The following is a description of a gene set: from publication Chen Y, Wang X (PMID 31504780) Mouse Gene Set: MIR_291A_3P_MIR_294_3P Genes predicted to be targets of miRBase v22 microRNA mmu_miR_291a_3p, mmu_miR_294_3p in miRDB v6.0 with MirTarget v4 prediction scores > 80 (high confidence targets). species: Mus musculus, and this is the list of marker genes: Lhx8, Txnip, Nhsl3, Med12l, Krt222, Akr1c21, Mtus1, Yod1 (NCBI Gene Id 76190), R3hdm1, Fzd3, Mospd2, Slc49a4, Kcnb1, Rab11a, Marchf8, Rps6ka1, Tle4, Skida1, Marchf11, Asap1, Pde3b, Myrf, Pcdh7, Pou6f1, Ube2q2, Tmtc1, Vmn1r45, Twf1, Prdm8 (PR domain containing 8), Retreg3, Asf1b, Zfp800, Ccnj, Unc80, Pak5, Mylk, Tet1, Synpo2, Uap1, Mtmr3, Fgd4, Crim1, Unk, Ythdf3, Cdkn1a, Nr2c1, Cnot6, Kat2b, Rab22a, Bcl11b (B cell leukemia/lymphoma 11B), Kmt5b, Fndc3a, Rock2, Prdm4, Cyp26b1, Asxl3, Vldlr, Nufip2, Tiparp, Ccnd1, Rbl1, Gpr158 (G protein-coupled receptor 158), Parp8, Zbtb41, Tmem123, Ube2b, Spop, Caprin2, Dcaf6, Ambn, Rnf150, Micu1, Zfp362, Ism2, Nr2c2, Slc5a10, E2f2, Ppp1r36, Lefty2, Hs2st1, Flt1, Plagl2, Unkl, Npas3, Armc8, Fam168b, Slc7a2, Erap1, Glis3, Zfyve26, Trpv6, Tfap4, Slc30a10, Ptpn21, Snx8, Slc22a23, Rb1cc1, Lats2, Hmbox1, Asf1a, Ddhd1, Dgkq, Dcdc2a, Arhgef17, Ryr2, Prdm16, Zkscan1, Taf1, Zfp827, Cdk6, Irf2, Nfib, Ssr1, Zfp148, Irf9, Sar1b, Zbtb43, Ednrb, Cpeb1, Ddias, Dpp8, Phc3, Epha2 (Eph receptor A2), Epha5, Sf3b1, Aak1, Mpc1, Ezh1 (enhancer of zeste 1 polycomb repressive complex 2 subunit), Wdr48, Macc1, Dcun1d4, Hlf, Erc1, Pak2, Nfia, Golga1, Srcin1, Ago1, Zfp367, Cdca7, Ikzf2, Tmub2, Zfp9, Tgfbr2, App, Zfp53, Rnf6, Ss18l1, Mettl21c (methyltransferase 21C, AARS1 lysine), Lhx6, Ptprb, Kpna2, Col17a1, Trim36, Mink1 (NCBI Gene Id 50932), Kif26b, Pip4k2a, Crot, Ash1l, Reep3, Smarcc2, E2f7, Clock, Coro2b, Miga2, Jazf1, Tnfaip1, Irf2bp2, Elk4, Rassf2, Bloc1s5, Rab5c, Suv39h1, Kremen1, Tiam1, Cnot6l, Syde1, Elavl2, Hif1an, Itgb8, Malt1, Lefty1 (NCBI Gene Id 98355), Ppp1r3e, Cluh, Smc2, Mier3, Pbx3, Nfya, 2410002F23Rik, Slc7a15, E2f5, Fgf9, Slc6a9, Rbl2, Tapt1, Mycn, Sowahc, Gpc6, Map3k14, Kmt2a, Rtn1, Arhgef10, F3, Suco, Slf1, Usp24, Ankrd17, Rgmb, Znrf3, Tnrc18, Mllt6, Rsbn1, Atxn1, Rnf216, Sdc1, Shc4, Cd200, Rab8b, Ect2, Zbtb11, Btg1, Trip11, Fgd5 (NCBI Gene Id 232237), Ncoa7, Cfl2, Map3k2, Lrat, Zbtb5, Osmr, Arid4b, Hipk3, Rictor, Prrg1, Adam9, Rest